Given this list of marker genes SMC1A, SRRM2, KANSL1, CDC40, CHMP2B, PRKAR1B, ATP7B, FKBP6, MED13L, BUD23, MAN2C1, TMTC3, CLTC, GABRG2 (gamma-aminobutyric acid type A receptor subunit gamma2), TBR1, NLGN1, OCA2, CACNA1G, PCDH19, METTL27, GM2A, MPLKIP, UCHL1, FMR1, JRK, GRIN1, APP, RNF113A, VPS13C, GABBR2, GTF2E2, TTC19, SYNJ1, NTNG1, LINGO1 (NCBI Gene Id 84894), SYNGAP1, SLC6A8, ATRX, TET3, PRKN, ABCA7, LIMK1, POU4F1, ARSA, LRAT, WARS2, TYROBP, GATAD2B, MED12, PIGH, DLK1, RPE65 (NCBI Gene Id 6121), SPTBN1, CLIP2, DYRK1A, PUS3, NOVA2 (NCBI Gene Id 4859), WDR4, CREBBP, TTI1, NEXMIF, PSEN1, TBC1D2B (TBC1 domain family member 2B), ERCC2 (NCBI Gene Id 7269), EIF4H, TELO2, LRRK2, VCP, HTRA2, DPYD, TBL2, SNCA, DNAJC30, NCF1, TARS1, TSC1, PARK7, NTNG2, AARS1 (NCBI Gene Id 16), TMEM106B, ERCC3, FOXG1, CARS1, PLA2G6, GABRA1 (NCBI Gene Id 2554), PODXL, CAMTA1, SLC6A1, COG6, SNRPN, SMARCA2, SORL1, TDO2, SHANK3, DCTN1, LCA5, TRANK1, GTF2IRD1, EIF4A2, MEG3, PSAP, GABRB3, EBP, OPHN1, GLI3, PGAP1, SH2B1, HERC1, HSD17B10, MAPT, PPIL1, APC2, PDE2A, GRIK2, VPS13A, ITPR1, CHMP1A, CHAMP1, GTF2IRD2, FOXP2, DDX59 (NCBI Gene Id 83479), SLC9A6, LNPK, GRN, SLC2A1, RTL1, CSF1R, SNX14, CIT, ADSL, SCN1A, ABCC8, AP2M1, PIGS, UBE3A, ZMYND11, PIDD1, IFNG, IQSEC2, GTF2H5, NF1, CACNA1H, AMPD2, CCNK, BAZ1B, MECP2, STX1A, CTNNA2, PTRHD1, SQSTM1, TUBB3, GTF2I, SLC6A17, ADNP, CNTNAP2, EP300 (E1A binding protein p300), CHD2, WLS, POGZ, PINK1, POLA1, ATP10A, CHD8, ELN (NCBI Gene Id 2006), SPATA7, TMEM270, RFC2, DNAJC6, VPS37D, MBD5, ALG11, TREM2, TSC2, CDKL5, PSEN2, TOMM40, here is a description of the gene set: Human Gene Set: HP_ABNORMAL_SOCIAL_BEHAVIOR Abnormal social behavior An abnormality of actions or reactions of a person taking place during interactions with others. studied in species Homo sapiens